The following is a description of a gene set: A stably positioned site of clathrin adjacent and physically attached to the postsynaptic specialization, which is the site of endocytosis of post-synaptic proteins. Human Gene Set: GOCC_POSTSYNAPTIC_ENDOCYTIC_ZONE species: Homo sapiens, and this is the list of marker genes: CLTA (clathrin light chain A), GRIA2, AP2A1, HIP1R, CALY, FCHO1, EPS15, AP2B1, ITSN1